Given this list of marker genes Atg13, Atg4a, Ulk2, Atg4c, Atg5, Snx30, Ulk3, Atg4d, Atg9a, Atg7, Atg4a-ps (autophagy related 4A, pseudogene), Rb1cc1, Snx7 (NCBI Gene Id 76561), Atg12, Ulk1, Atg2b, Atg2a, Atg9b, Atg4b, here is a description of the gene set: Degradation of a cell nucleus by microautophagy. Mouse Gene Set: GOBP_PIECEMEAL_MICROAUTOPHAGY_OF_THE_NUCLEUS studied in species Mus musculus